The following is a description of a gene set: Mouse Gene Set: GOBP_REGULATION_OF_SMALL_GTPASE_MEDIATED_SIGNAL_TRANSDUCTION Any process that modulates the frequency, rate or extent of small GTPase mediated signal transduction. species: Mus musculus, and this is the list of marker genes: Dab2ip, Rabgef1, Amot, Dennd4a, Notch1, Rdx, Abl1, F11r, Adcyap1r1, Mmd2, Grin2a, Rasal1, Sipa1l3, Psd, Arhgap35, Arf6, Kank1 (KN motif and ankyrin repeat domains 1), Cadm4, Mfn2, Abra, Arhgap29, Arhgap17, Dennd4b, Arhgap22, Csf1, Arhgap24, Wnk1, Spry1, Sema4d, Kank2, Rasip1, Dgki, Frmd7, Kctd13, Agrn, Flot1, Rasgrp1, Dynlt1b, Arhgap44, Gmip, Map2k1, Rasal3, Spry4, Ephb2, Rapgef1, Apoa1, Sipa1l1, Rap1gap2, Dynlt1f, Kif14, Prag1, Lrp4, Rab3gap1, Gbf1, Syngap1, Dennd4c, Apoc3, Tgfb2, Ppp2cb, Cyrib, Ralgapb, Dennd3, Arhgap28, Rasgrf1, Tgm2, Dock10, Stmn3, Sh2b2, Stk19, Rasa4, Rit2, Dock2, Dgkz, Stard8, Camk2d, Musk, Fnta, Tsc2, F2r, Sh3bp1, Lpar1, Robo1, Rabl3, Sgsm3, Sipa1l2, Git2, Fbp1, Garnl3, Src, Picalm, Reln, Gpr4, Dnm2, Cdc42se1, Arhgef18, Map4k4, Rtn4, Arhgap12, Tns3, Cyth2, Arfgap1, Met (met proto-oncogene), Ogt (NCBI Gene Id 77137), Spry2, Flcn, Ripor1, Adgrg1, Dock9, Abca1, Cdc42bpa, Ntrk1, Rasa2, Akap13, Stard13, Synpo2l, Arfgef3, Cdc42se2, Dock7, Rtn4r, Eps8l2, Dock8, Psd3, Lpar2, Arhgap20, Dynlt1c, Fermt2, Shoc2, Pdgfrb, Lztr1, Crk, Sos1, Dennd1a, Git1, Psd4, Chn1, Hras, Kbtbd6, Rgl2, Arhgef2, Arhgap42, Madd (NCBI Gene Id 353087), Cbl (Casitas B-lineage lymphoma), Dlc1, Arrb1, Iqsec1, Arfgef2, Arhgap18, Mapre2, Icmt, Itgb1 (NCBI Gene Id 70812), Stambp, Grin2b, Ralgps1, Rasa3, Kbtbd7, Dok7, Fxr1, Syde2, Myo9b, Kctd10, Adra1a, Kras, Csnk1a1, Tagap, Adra1b, Dock6, Cyth1, Apoe, Notch2, Nf1, Itgav, Cyth3, Igf1 (insulin-like growth factor 1), Arhgap45, Arhgap19, Fbxo8, Nrp1, Eps8l3, Rap1gap, Mapkap1, Ralbp1, Cdh2, Cgnl1, Cd2ap, Arhgap25, Dynlt1a, Tnfaip1, Eps8l1, Net1, Crkl, Iqsec2, Gpr55, Nup62, Timp2, Ssx2ip, Ralgapa2, Syde1, Cul3, Erbb2, Tnk1 (tyrosine kinase, non-receptor, 1), Rasgef1a, Stmn1, Abl2, Arhgap40, Foxm1, Iqsec3, Ngf, Arhgdia, Arfgef1, Ripor2, Arhgdib, Bcr, Epo, Scai, Slit2, Psd2, Plxnb1, Myoc, Col3a1, Eps8, Heg1, Cdon, Sos2, Bcl6, Kitl, Fgf10, Sipa1, Mcf2l, Pik3cb, Dock11, Bnip2, Nrg1 (NCBI Gene Id 320603), F2rl1, Gabarap, Cyth4, Pik3cg, Ralgapa1, Arhgef28, Arhgef3, Ophn1, Trim67, Itpkb, Ngfr, Ccdc125, Itga3, Auts2